Given this list of marker genes RUNX2 (NCBI Gene Id 860), CACNA1C, HOXD10, RSPO2, LNPK, CTNNB1, RDH10, IFT122, RPGRIP1L, NIPBL, TBX3, TBX5, ARK2C, HOXA11, TFAP2B, WNT7A, OSR2, ALX4, HOXD9, TWIST1, MSX2, HOXA13, HOXA9, WNT3, EN1, VPS54, TP63, ATRX, ZNF358, ALDH1A2, ZBTB16, GDF5, ALX3, OSR1 (odd-skipped related transcription factor 1), TFAP2A, RECK, CRABP2, MSX1, SHOX2, SHH, here is a description of the gene set: species: Homo sapiens Human Gene Set: GOBP_FORELIMB_MORPHOGENESIS The process in which the anatomical structures of the forelimb are generated and organized. The forelimbs are the front limbs of an animal, e.g. the arms of a human.